Given this list of marker genes DNAAF9, GOLGA1, HNF1B, ACOX1, BCAT2, FNBP4, ZNF721 (zinc finger protein 721), AFF3, MSR1, GLYR1, PDZD2, NKX2-4, GPC6, RSBN1, PDZD8, C5orf24, C19orf12, SNAPC1, RGL1, ROBO2, OTUD4, KAT2B, ST6GAL2 (ST6 beta-galactoside alpha-2,6-sialyltransferase 2), FZD10, GOLGA7, G3BP2, EDEM3, EFR3A, KLHDC10, LRCH1, PCGF3 (polycomb group ring finger 3), EDEM1, FXR1, ABHD13, DOCK9, PLEKHB2, FAM24A, AADACL3, KLHL29, PRRC2B, GPR158, ATG14, GPR180, CPEB3, GTF2A1, TMEM229A, DENND4B, ELOA, CBFA2T3, USP45, ITPRID2, ANKRD28, PNISR, AGO3, ZNF24, LONRF3, SCAF11, PGBD2, FBN1, COL19A1, ZFAND1, ATP6V1B2, SCN8A, STYX, LUZP1, HAND2, CPEB2, YIPF4, GATA2, NEFM, BSDC1, NCAPH2, CLCN5, ADRB1, STRN3, MAP3K20, ARMC1, MINAR1, WASL, ZFC3H1, DUSP10, ELK4, ARHGEF17, ADAM10, NKX2-3, NCKAP5, MPP1, FKBP1A, ARF1, DNAJB12, INSIG1, XYLT2, SPTBN4, PCDH11Y, ADAM19, ANP32E, ERGIC2, CPEB4, PCOLCE2, IQGAP2, GLCE, ANO8, PTPRD, GLRA1, TBC1D12, RBM27, PCDH11X, FAM20C (FAM20C golgi associated secretory pathway kinase), PTPRK, MARCHF4, JOSD1 (NCBI Gene Id 9929), TPPP, COX20, IL36B, CDK16, TGIF1, TMEM255A, NSF, ANKIB1, NEFL, TBC1D8, SLC25A32, LMBR1L, CNEP1R1, NPC1, TMEM267, SRPRA, CHCHD10, IDH1, LIN54, CLDN11, MORC3, GIT2, BCL11B, PAX9, DDX3Y, P3H3, TBL1XR1, UBE2W, MYO1B, BAZ2B, ZNF595 (NCBI Gene Id 152687), RIC1, DDX3X, LATS2, SOCS6, RNF180, GRHL1, KLF2, CELF2, FOXN2, DUSP5, CIC, SLC9A7, ZEB2, KLF8, VPS4B, FNIP1, XPNPEP3, FHIP1B, FAM135A, USP36, SPRYD4, WWP2, DNAJB9, CADM2, DMXL1, KLF4, BCL11A, PIK3CB, NUFIP2, FHL2, C21orf91, RPS6KA4, ELOVL4, ADAMTSL3, GPR137C, NF2, PER2, DENND1B, ANKRD44, ITGA8, NRG1, DAAM1, PALLD, ASPN, LHFPL2, ZNF827, PLEKHG3, CNIH1, TET2, PLEKHA1, SGK3, GNPDA2, PCDH7, MOAP1, JMY, LYST, PKDCC, SERTAD3 (NCBI Gene Id 29946), MEF2D, SYNJ1, SELENOT, SLC7A11, C11orf24, PCMTD1, EPC2 (NCBI Gene Id 96643), ADCY3, EVI5, SLC25A36, GOLGA3 (golgin A3), USP28, RAB8B, PHLPP2, RNF38, NFYB, SLX4, SOSTDC1, FNIP2, ITGA6, CD69, PAX3, SLC25A16, CUX1, MIER1, PEAK1, CBLN4, CDH10, DUS2, FMN2, PPP1R12C, TEF, CTTNBP2, SNN, ATXN3, SH3PXD2A, DSC2, MAP1B (microtubule associated protein 1B), CCNJL, TAFA1, SSBP2, MAN2A1, DPP10, HIPK3, PPCS, ZDHHC5, FCHO2, GOLGA4 (NCBI Gene Id 2803), PRKAR2B, AIDA, CDKL5, NSMF, PDE10A, C8orf44-SGK3, RGS3, MACIR, PAPSS2, SERINC5, RAB14, ATXN1 (NCBI Gene Id 7912), NPNT, MMP10, MYO5A, COG3, GID4, BLTP1, PTGER4, TMF1, TCF21, UBE2Z, GATA6, MIA3, MCL1, BCL2L11 (NCBI Gene Id 150819), EOMES, MFHAS1, FBXW7, MED19 (NCBI Gene Id 219541), RBM47, SLC12A5, HERPUD2, NOX4, MAPK8, PIK3R3, TACC2, SOX11, BTG2 (BTG anti-proliferation factor 2), GNAQ, BMPR2, ZNF287, PCYT1B, ACTC1, UBXN4, FRY, PSMD14, CCNC, ADAMTSL1, PITPNM2, EPG5, SLC38A2, APBB2, SCUBE3, RGS17, TTC9, IBTK, PIAS4, ESRP1, LIMCH1, RORA, KBTBD8, RPL15, HIVEP1, NR4A3, TAGAP, RNF44, CACNA1I, MYCBP2 (NCBI Gene Id 55685), UCHL5, RNF4, TOB1, MFF, PHTF2, MAGEC2, ATRX, MBOAT2, TEAD1, MAST4, PTAR1, CCDC186, TRIM36, RANBP9, ARID1B, MMD, TOB2, SLC4A8, SNX13, MTMR9, ZNF521, MAP2K4, DYRK2, ADGRF2P, SH3D19, RHPN2, CDCA7L, SLC39A8, KLHL15, LRRC1, UBASH3B, SGPP1, PTPRO, SLC32A1, CPNE8, PTPRJ, COL1A2, HYCC2, CXCL5, ZNF385D, SYN2, BAHCC1, MTF1, ARRDC3, TULP4, ITGAV, PLXDC2, HS3ST5, PTEN, SLC10A7, SLC9A1, GRAMD2B, ALKAL2, ARRDC4, APPL1, ITPR1, SEMA3A, ZFYVE21, B3GALT2, PITPNA, RAB23, RIMS2, RAD21, SESN3, TRIO, KMT5B (lysine methyltransferase 5B), REST, MARCHF6, KLHL14 (NCBI Gene Id 57565), RAB3C, PIKFYVE, REXO1, SLC24A3, ZC2HC1A, TNPO1, ITGA5, RFX1, PPP1R37, COL27A1, FHIP2A, GFPT2, PAXBP1, SLC17A6, TENT4A, OTUD3, HIPK1, NSMAF, UGP2, NEFH, SOX4, CALN1, ZFHX4, TECPR2, DCAF6, SNAP91, RNF141, OSBPL5, TPCN1, TEX2, HCN2, PPP1R12A, ARHGAP24, TWF1, here is a description of the gene set: studied in species Homo sapiens Human Gene Set: MIR25_3P from publication Chen Y, Wang X (PMID 31504780) Genes predicted to be targets of miRBase v22 microRNA hsa-miR-25-3p in miRDB v6.0 with MirTarget v4 prediction scores > 80 (high confidence targets).